Given this list of marker genes Jarid2, Ptx3, Slc44a1, Tmem171, Cd86, Sema4c, Traf3ip2, Tor1aip2, Arhgap26, Nod1, Zdhhc21, Rel, Malt1, Tnfaip3, Wdr59, Tmco3, Tra2a, Rigi, Cnn3, Chd1, Tmem219, Slc16a1, Prr5l, Zbtb32, Tjp2, Il6, Gbp7, Nsd3, Ctla2b, Fas, Il10, Casp12, Il12b, Chst11, Ppp1r15b, Chd7, Dcp1a, Cp, Vezt, Rap2c, Gnb4, Tnc, Sp110, Cxcl11, A630072M18Rik, Trim26, Slc30a4, Zfp281, Cd69, Atp11b, Nos2, Trip10, Atp10a, Mndal, Odc1, Ptprj, Tet2, Syne3, Nfkb1, Aff1, Ncoa7, Srsf3, Mgat4a, Iqsec2, Tmem50b, Gk, Rcan1, Ikzf1, Cmtm6, Homer1, Gm15337, Hmgn3, Cenpj, Entr1, Mapkbp1, Mpp7, Tmem229b, Pmepa1, Casp7, Tlk2, Il4i1, Plekha4, Ppa1, Ranbp2, Trmt61b, Slco3a1, Fos, Rin2, Slc25a22, Mtfr2, Itgb8, Snn, Prpf4, Alcam, Mxd1, Arf4, Ktn1, Nup58, Cxcl3, Vcam1, Socs7 (suppressor of cytokine signaling 7), Pdss1, Camk2d, Rhbdf2, Etv3, Nek6, Cebpd, Aida, Pou3f1, Tagap, St6galnac4, Trim21, Noc4l, Nectin2, Nr3c1, Golga3, Olr1, Shfl, Serpine1, Nfkbid, Foxp4, Tlr3, Myadm, Col27a1, Gm11772, Zbtb8a, Jdp2, Sec24b, Pla2g4a, Tnfrsf12a, Gca (grancalcin), Cds1 (CDP-diacylglycerol synthase 1), Col18a1, Fez2, Ezr, Tiam1, Cdkn1a, Noct, Lipg, Nampt, Sertad3 (SERTA domain containing 3), Tnfsf10, Adamts4, Cited2 (NCBI Gene Id 17684), Pcgf5, Il33, Mt1, 9330175E14Rik, N4bp1, Mir155, Cxcl1, Adap2, Fmr1, Cd40, Myo10, Bltp1, Pdzk1ip1, Rnd1, Xrn1, Mcf2l, Mfsd6l, Foxp1, Rnd3, Plekha2, Pde4b, Tab2, Eng, Rai14, Atp9b, Bcl3, Rmdn3, Sfpq, Src, Dgka, Nlrc5, Aebp2, Plagl1, Dcp2, Dgkh, Ppm1k, Rilpl1, Dusp2, Batf2, Map2k4 (NCBI Gene Id 26398), Tcf4, Otud1, Nfil3, Znrf3, Ifi202b, Map3k8, Ubash3b, Dll1, Slc39a14, Gypc, Dram1, Whamm, Ctla2a, Gpr84, Slfn5 (schlafen 5), Prkx, Hbegf, Dusp5 (NCBI Gene Id 240672), Samhd1, Mtmr7, Cgas, Schip1, Pml, Fam32a, Arel1, Fancc, Mitd1, Tut7, Parp14, Ripk2, Setdb2, Smim36, Ifih1, Gpsm2, Luzp1, Kat6a, Dennd6b, Phldb1, Gbp3, Tpm4 (tropomyosin 4), Stx6, Aim2, Tasor2, Slc4a7, Tmem30a, Tmem243, Etv6, Cacnb3 (calcium channel, voltage-dependent, beta 3 subunit), Icosl, Arhgef3, Klf7, Edn1, Zyx, Gadd45g, Slc30a1, Lhx2, Xkr8, Fam241a, Septin11, Spata13, Slc2a6, Tent4a, Tpbg, Fkbp5, B4galt5, Glipr2, Flnb, Rgs16, Nfkbiz, Notch1, Stat3, Ptgs2, Nfxl1, Tmtc2, Etnk1 (ethanolamine kinase 1), Med13l (mediator complex subunit 13-like), Abtb2, Mtus1, Fzd5, Upp1, Creb5, Fnbp4, Igtp, Fscn1, Apaf1, Tubb6 (NCBI Gene Id 67951), Ifi203, Itpkb, Socs3, Tiparp, Cav1, 5033421B08Rik, Pphln1-ps1, Vcan, Nectin4, Gspt1, Lrrfip1, Socs2, Uaca, Phc2, Ccnd2, Katna1, Dennd1b, Csrnp1, Mt2, Rnf125, Rffl, Rbl1, Snx10, Fzd1, Pik3r6, Adgrg6, Tnfsf4, Zfp36, Lck, Hopx, Lnpk, Pim1, Il13ra1, Phip, Il1b, Tal1, Ppfibp1, Zfp800, Minpp1, Mtmr14, Filip1l, Plod2, F2r, Pfkfb3, Zup1, Parp8, Tnfsf9, Arid5a, Dusp14, Ilrun (inflammation and lipid regulator with UBA-like and NBR1-like domains), Niban1, Rac3, Frmd4a, Bfar, Adgrl2, Serpina3g, Rcn1, Tpst1, Sdc4, Hspa1b, Ccl22, Traf1, Lpar1, Mafk, Ext1, Fmnl2, Stat5a, Grk3, Tanc1, Agrn, Akt3, Plekhf2, Mx2, Il15, Exoc3l4, Tnfsf8, Ogfrl1, Zeb1, Khdrbs1, Asb13, 4930434J08Rik, Jak2, Rhoh, Inpp1, Gcnt2, Lmna, Daam1, Gja1, Selp, Mmp13 (NCBI Gene Id 17386), Junb, Bcl9, Il15ra, Il4ra, Plaur, Igsf9, Daxx, Spred1, Slc45a3, Lcp2, Zc3h7a, Shisa3, Sgk3, Marchf5, Mob3b, Wdr43, Lrch1 (leucine-rich repeats and calponin homology (CH) domain containing 1), Ctnnal1, Gramd1a, Tbc1d1 (TBC1 domain family, member 1), Errfi1, Ctsc, Usp12, Tle3, Gna15, Arl4a, Gng4, Sphk1, Kremen1, Ch25h, Gda, Spsb1, Cemip2, Hivep2, Csf1, Lancl2, Sectm1a, Kpna3, Ptprd, Il18 (NCBI Gene Id 16173), Slc12a4, Endod1, Vcpip1, Armc8, Socs1, Dnaja2, Sertad1, Nfix, Tma16, Hdc, Irf2, Itgav, Usp42, Car2, Prpf38a, Gbp9, S100a10, Macir, Slfn3, Pdlim5, Mier3, Dusp16, Angpt1, 9430034N14Rik, F11r, Hhex, Cd83, Slfn9, here is a description of the gene set: studied in species Mus musculus Class NT (non-tolerizeable) genes: induced during the first LPS stimulation and induced at equal or greater degree in tolerant macrophages. Mouse Gene Set: FOSTER_TOLERANT_MACROPHAGE_DN Toll-like receptors (TLRs) induce a multi-component inflammatory response that must be tightly regulated to avoid tissue damage. Most known regulatory mechanisms target TLR signalling pathways and thus broadly inhibit multiple aspects of the inflammatory response. Given the functional diversity of TLR-induced genes, we proposed that additional, gene-specific regulatory mechanisms exist to allow individual aspects of the TLR-induced response to be differentially regulated. Using an in vitro system of lipopolysaccharide tolerance in murine macrophages, we show that TLR-induced genes fall into two categories on the basis of their functions and regulatory requirements. We demonstrate that representatives from the two classes acquire distinct patterns of TLR-induced chromatin modifications. These gene-specific chromatin modifications are associated with transient silencing of one class of genes, which includes pro-inflammatory mediators, and priming of the second class, which includes antimicrobial effectors. These findings illustrate an adaptive response in macrophages and reveal component-specific regulation of inflammation. from publication Foster SL, Hargreaves DC, Medzhitov R (PMID 17538624)